Given this list of marker genes GARIN3, FOLR3, DCST2, TMEM81, ADAM2, SPACA3, FETUB, HSPA1L, ASTL, SPAM1, ADAM32, IZUMO1R, CCT2, ZP3, UBAP2L, PCSK4, ZP1, ACR, SPACA4, TMPRSS12, CCT8, ZP4, OVGP1, LY6K, ADAM18, PRSS37, ATP8B3, CCT5, TEX101, SPA17, CRISP1, CCT3, B4GALT1, TCP1, VDAC2, ZAN, FOLR2, ZPBP2, DCST1, FREY1, IZUMO1, ZPBP, CD9, FOLR1, CLGN, PRSS55, ALDOA, SPPL2C, CCT7, ZP2, SPACA6, CCT4, PAEP, SPESP1 (sperm equatorial segment protein 1), here is a description of the gene set: The initial contact step made between the sperm plasma membrane and outer layer of the egg during fertilization. Human Gene Set: GOBP_SPERM_EGG_RECOGNITION species: Homo sapiens